Given this list of marker genes GLI3, ROR2, TWIST1, BGN, KNSTRN, IFT43, DVL1, PRMT7, SETD5, FIG4, SMARCA2, LRP4, BRF1 (BRF1 RNA polymerase III transcription initiation factor subunit), HOXD13, PIGF, PPP2R3C, NXN (NCBI Gene Id 64359), ARID1B, PIGB, PGAP2, EDA, PITX1, SPTBN1, MCTP2, PIGW, SALL4, COL2A1, PTCH1, LMNA, HNRNPR, CHUK, PRKACB, GNAS, SMARCB1, ARID1A, MGP, PIGV, CTSK, CWC27, MACROH2A1, CHST3, UBAP2L, TBC1D24, EVC2, SETBP1, IHH, SF3B4, WNT5A, B3GALT6, GPC3, RNU4ATAC, UNC80, ZMPSTE24, IFT57 (intraflagellar transport 57), KDM5C, FLNA, SMARCE1, IARS1, MAP3K7, B3GAT3, CANT1, FTSJ1, FGFR2, GLI1, DLK1, CREBBP, ASCC3, PCNT (pericentrin), AMMECR1, CCDC22, NFIX, COL10A1, MRPS28, MAPK1, NALCN, VAC14, PIGL, ACTL6B, PIGY, RBPJ, RAB3GAP2, ERI1, GPC4, IGF2, TRPS1, ACP5, RTL1, RMRP, TRPV4 (transient receptor potential cation channel subfamily V member 4), CRKL, MTOR, PIGO (phosphatidylinositol glycan anchor biosynthesis class O), GGCX, PIGS, DOCK6, ALG6, CHST11, TFAP2B, EVC, HS2ST1, BANF1, LEMD3, SLC25A24, MEG3, EXOSC2, GDF5, IFT122, WDR19, GNPNAT1, EP300, CRIPT, EDA2R, NOTCH2, IFT52, JAG1, LBR, NOG, STAMBP, POR, WDR35, VPS35L, EOGT, ZBTB20, PIGN, TGFBR2, KCNJ8, FTO, POC1A, TBX3, ARHGAP31, KIF22, PAH, FLNB, FBXO11, ADAMTS15, ABCC9, PTHLH, SOX11, GJA5, RAB3GAP1, CBFB, PHF6, DSP, RPS6KA3, PGAP3, GATAD2B, NOTCH1, COG4, DYNC2LI1, PIK3CD, KCNN3, SOST, HOXA13, GJA8, FN1, BCR, PDGFRB, DDR2, ATP6V1B2, KCNH1, BMPR1B, NSDHL, DLL4, ARSL, KIF7, COMP, CTSC, CLCN7, SRCAP, WLS, PRKACA, here is a description of the gene set: Any anomaly of distal phalanx of finger. Abnormal distal phalanx morphology of finger studied in species Homo sapiens Human Gene Set: HP_ABNORMAL_DISTAL_PHALANX_MORPHOLOGY_OF_FINGER